Given this list of marker genes Ly6d, Onecut2, Nsg1 (neuron specific gene family member 1), A830018L16Rik, Kalrn, Marchf4, Tmpo, Nr4a2, Traf2 (NCBI Gene Id 98924), Tpx2, Tnpo2, Map3k20, Syt7, Islr2, Kcnj4, Cxcl12, Zfp275, Amigo3, Nup62, Tmem229b, Ubp1, Dap3, Slc17a8, Zbtb4, Sema4c, Nkx3-1, Agap2, Fbrs, Nptx1, Mybpc1, Nfib, Kdm5c, Kxd1, Rubcn, Eepd1, Adcy5 (NCBI Gene Id 224129), Grm4, Fuca1, Avpr2, Fam187a, Dio3, Tnfrsf1b, Ccdc121rt2, Myo18a, Gprc5b, Pde4a, Chkb, Fem1a, Cttnbp2nl (CTTNBP2 N-terminal like), Srxn1, Ago1, Unc119b, Osbpl3, Fkbp5, Dennd4c, Pelo, Sdhd, Ipcef1, Map6 (NCBI Gene Id 17760), Adcy6, here is a description of the gene set: studied in species Mus musculus from publication Chen Y, Wang X (PMID 31504780) Mouse Gene Set: MIR_702_3P Genes predicted to be targets of miRBase v22 microRNA mmu_miR_702_3p in miRDB v6.0 with MirTarget v4 prediction scores > 80 (high confidence targets).